The following is a description of a gene set: Human Gene Set: chr10q23 species: Homo sapiens, and this is the list of marker genes: BMS1P3, MIR4679-1, EIF4A1P8, RNU6-529P, CYP2C19, AGAP11, LINC01375, FAS, GRID1-AS1, KLLN, NRG3, CYP2C9, PDE6C, ENSG00000273124, GHITM, MIR4678, FAF2P1, LGI1, CYP2C8, CFL1P1, WAPL, CEP55, GRID1, CYP26C1-DT, DYDC2, IFIT1, PAWRP1, CYP2C60P, ACTA2-AS1, CYP26C1, ACSM6, PPP1R3C, ENSG00000296045 (NCBI Gene Id 124902551), ACTA2, MLDHR, ADIRF, PANK1, HELLS, RPP30, OPN4 (opsin 4), RN7SL78P, MIR346, CERNA2 (NCBI Gene Id 647734), MTND4P20, MTND5P42, MARK2P15, SLC35G1, MARCHF5, RNU6-478P, MED6P1, BTAF1, FAM245A, TSPAN14-AS1, RPA2P2, MARK2P9, MIR4679-2, RPAP2P1 (RNA polymerase II associated protein 2 pseudogene 1), CCSER2, PIPSL, LIPN, SLC16A12-AS1 (NCBI Gene Id 101926906), ENSG00000298970, TBC1D12, PCGF5, LIPK, RNU6-325P, IFIT1B, PLCE1-AS1, DDX18P6, CACYBPP1, ENSG00000307213, ENSG00000287057, GPR15LG, ANKRD1, LINC01520, LIPJ, KIF11, CYP2C59P, RAB11AP1, SH2D4B, LRIT2, PTCD2P2, XRCC6P1, CTBP2P2, LINC02655, ADIRF-AS1, LINC00502, RCBTB2P1, LINC00858, TNPO1P1 (transportin 1 pseudogene 1), IDE, EIF2S2P3, LDB3, TNKS2-DT, HDAC1P1, RPS3AP5, RNA5SP322, FFAR4, MMRN2, STAMBPL1, RPL12P29, RNY3P12, RPL7AP8, IFIT3, CYP2C58P, RNU1-19P, LIPF, LINC02647, NUDT9P1, NUTM2D, SNCG, PDLIM1, NHP2P1, NRG3-AS1, HTR7, NUTM2A, PLCE1-AS2, EXOC6, FRA10AC1, RNU6-657P, CH25H, FARSBP1, DYDC1, IFIT6P, ENSG00000224504, ATAD1 (NCBI Gene Id 84896), RN7SL733P, RNU6-441P, HECTD2-AS1, RPS27P1, CDHR1, RPS26P38, NOC3L, BMPR1A, LRIT1, SDHCP2, RNA5SP323, LIPM, HECTD2, MYOF, MINPP1, LINC02650, ENSG00000200891, TNKS2, NUTM2A-AS1, PANK1-AS1, GAPDHP28, RNLS, RNU6-740P, PLCE1, RNU1-65P, RPL11P4 (NCBI Gene Id 100271272), RPL7P34, LINC01519 (NCBI Gene Id 101929624), ENSG00000286359, IFIT5, FAM25A, WAPL-DT (NCBI Gene Id 124906907), SNRPD2P1, RN7SL644P, NAPGP1, PRXL2A, RN7SKP238, RNU6-780P, ANKRD22, KIF20B, RGR, HMGN2P8, WARS2P1, HHEX, PTEN, SHLD2, PAPSS2, MARK2P16, CTSLP1, RPL7AP52, TSPAN14, LINC00863, RN7SKP143, LINC00865, CPEB3, GLUD1, RPL17P34, RPS7P9, IFIT2, NPAP1P3, LINC02653, SLC16A12 (NCBI Gene Id 387700), MTND4P19, LIPA (lipase A, lysosomal acid type), RPL11P3, RBP4, NIP7P1, KRT8P38, FGFBP3, MIR107, CYP26A1, RNU6-129P, SRP9P1, CYP2C18